The following is a description of a gene set: This event has been computationally inferred from an event that has been demonstrated in another species.<p>The inference is based on the homology mapping from PANTHER. Briefly, reactions for which all involved PhysicalEntities (in input, output and catalyst) have a mapped orthologue/paralogue (for complexes at least 75% of components must have a mapping) are inferred to the other species. electronically inferred by orthology from the curated human pathway part of: Chromatin modifying enzymes Reactome Pathway: PKMTs methylate histone lysines species: Mus musculus, and this is the list of marker genes: H4c4, Prdm9, H4c3, Prdm16, H3c1, Ehmt1, H4c18, H4c1, H3c3, H4c9, Nfkb1, H3c6, Smyd3, H4c2, Kmt5c, H4c17, Ash2l, Setd1a, Setd6, H3c15, H3c10, H4c6, H3c8, H3c7, Ezh2, Rela, H3c11, Kmt5b, H4c12, Setd7, H4c11, Rbbp7, Kmt2b, Nfkb2, H3c2, Dot1l, H3c4, Rbbp4, H4c14, H3c13, H4c8 (NCBI Gene Id 69386), Suv39h1